The following is a description of a gene set: species: Homo sapiens Human Gene Set: HP_PROGRESSIVE_CEREBELLAR_ATAXIA Progressive cerebellar ataxia, and this is the list of marker genes: TBK1, VPS13D, CACNA1A, PRNP, VCP, SLC44A1, KCND3, KCNC3, ANO10, PNPT1, RFC1, ATXN7, TARDBP, GJB1, ATXN3, MVK, DKK1, KCTD7, ATM, MARS2, ATN1, SCYL1, ZFHX3, TMEM240, ELOVL4, HTT (huntingtin), PDYN, CLCN4, MTPAP (NCBI Gene Id 55149), PRKCG, FUS, DARS2, PEX10, CHCHD10, POLG, MSTO1, ENSG00000288330, MT-TE, TPP1, COQ8A, SACS, ATXN10, ATP13A2, PRDM8, PPP2R2B, WFS1, PEX6, ATXN8OS, ATP6V0A2, SPTBN2, SLC25A15, TTPA, VPS41, GBA2, MME, AUH, SQSTM1, COQ2, TTBK2, TGM6, ATXN2, ATXN1, GLS, EEF2